The following is a description of a gene set: studied in species Homo sapiens The process in which a protein is transported across a membrane. Human Gene Set: GOBP_PROTEIN_TRANSMEMBRANE_TRANSPORT, and this is the list of marker genes: BCR, SEC61G, TRIP11, SEC61A2, SEC61B, PEX10, DNAJC19, ROMO1, TOMM20, TIMM21, TOMM22, PEX6, USP9X, RAB11A, PEX5, TIMM17A, BLOC1S6, TIMM22, TOMM40, EDNRA, TIMM17B (NCBI Gene Id 10245), SEC62, EXOC4, PEX14, GFER, PAM16, PEX2, EXOC7, DNLZ, PEX13, MCL1, AZGP1, SEC63, DTNBP1, PRF1, HSPA5, AIFM1, TRAM1L1, GRPEL1, PEX5L, HSPA4, TIMM23, PEX12, RTN2, PEX26, PEX16, TRAM2, GLP1R, TIMM23B, TOMM40L, EDNRB, BLOC1S3, AP4M1, HSP90AA1, ZFAND2B, PEX1, GRPEL2, SRP54, PEX7, TOMM70, C2CD5, TOMM7, DNAJC15 (DnaJ heat shock protein family (Hsp40) member C15), TRAM1, HPSE, IFT20, TMED10, SEC61A1, HSPD1, TIMM44, ABCA1, TIMM50, TRIM37, CHCHD4, SAMM50, TOMM20L, LONP2